The following is a description of a gene set: species: Mus musculus Mouse Gene Set: REACTOME_DISPLACEMENT_OF_DNA_GLYCOSYLASE_BY_APEX1 Displacement of DNA glycosylase by APEX1, and this is the list of marker genes: Mpg, Mutyh, Apex1, Tdg, Mbd4, Nthl1, Ung, Smug1, Ogg1